The following is a description of a gene set: studied in species Homo sapiens Excision from the chromosome and circularization of a region of chromosomal DNA, generally, but not always, via homologous recombination between direct tandem repeats. Human Gene Set: GOBP_FORMATION_OF_EXTRACHROMOSOMAL_CIRCULAR_DNA, and this is the list of marker genes: TERF1, SMARCAL1, NBN (NCBI Gene Id 4683), TERF2, WRN, SLX1B, RTEL1, ERCC1, XRCC3, DNA2, XRCC5, SLX1A, SLX4, EXO1, BLM